Given this list of marker genes ANKRD28, RARRES2, ORMDL2, DAB1, PRR5, CCNA1, COL6A1, PRPF39, CTNND2, NOTCH4 (NCBI Gene Id 4855), ATE1, TGFB2, YIF1A, CUL1, SRY, HLA-G, LTF, SNORC, VPS16, CLVS1, FUT9, CASQ1, STK25, SLC25A15, S100A4, CETN1, INTS14 (integrator complex subunit 14), HOXA4, IRF7, EBP, TMEM168, PTPRB, SSR1, PEG10, PGR, PKIB, BAAT, MYH6, DNPH1, SNCA, KCNK7 (potassium two pore domain channel subfamily K member 7), AADAC, DPYSL4, EPHB6, RRAGD, CDC37, TMEM266, MMS19, SERPINF2, ASL, CNTN1, APOF, INPP4A, ACTR6, C9orf85, TCF21, GHRH, ACTN2, BHMT, HLA-A, MYCN, UBE2J2, SOX5, CRAMP1, ILRUN, SOX2, PNMT, SLC35B2, PLD4, NRGN, CSF3R, MAPK13, SUPT6H, CPSF7 (NCBI Gene Id 79869), COQ9, COMMD5 (COMM domain containing 5), INTS5, CLEC3B, RETN, ACY3, ZNF865, RPS6KA4, TGFB3, DPPA2, GPR143, DALRD3, GNAT2, RPL35A, GBA1, RBL2, GTPBP2 (NCBI Gene Id 54676), MYH3, SOD1, SMTN, PRRC1, CLEC16A (C-type lectin domain containing 16A), ERG28, BHLHE40, GUCA1A, PER3, HMGCR, TENM4, RAF1, AVPR1A, H1-3, KIAA1217, FERMT3, LCAT, DTD2, SMC6, DHRS7B, USP17L2, PDLIM1, MOGAT2, ITK, INS, RETSAT, SCGB1A1, RAI2, PRAP1, ZG16, ADRA1A, FGF6, POLB, RPA1, ZMAT3, EPYC, XIRP1, KGD4, GLRA1, BCL7B, AP2M1, LIMK1, NDUFA12, KRTAP19-5, MYNN, RIC8A, BEX1, MTCP1, C1orf174, SRPK3, EPHA3, PIGF, ARHGEF2 (Rho/Rac guanine nucleotide exchange factor 2), DDR2, METTL17, ZIC1, SFN, IDH1, FLT3LG, EFNA3, CYP7B1, PLA2G7, RABEPK, FGF5, TOMM40, SLC25A19, BAIAP2, HIPK1, COP1, SLC1A1, IGLC7, UBE2F, SCG3, IQGAP2, ADA, BNIP2, HAGH, ASAH1, WNT5B, ADGRL1, MAP3K11, TMOD3, MRPL12, VAMP8, TUBA3C, TM4SF5, CNGA1, AKR1C4, STRN4, TRIM11, CBX6, WDR55, RING1, GGPS1, B4GALT3, FAP, COL4A4, COL26A1, FKBP5, CBX7, PLPP1, IRF3, HSD17B2, MAD2L1BP, CIITA, C1R, TBRG1, MCCC1, ANG, here is a description of the gene set: Genes down-regulated in CD42 int cells from thymus: T reg versus T conv. from publication Toker A, Engelbert D, Garg G, Polansky JK, Floess S, Miyao T, Baron U, Düber S, Geffers R, Giehr P, Schallenberg S, Kretschmer K, Olek S, Walter J, Weiss S, Hori S, Hamann A, Huehn J (PMID 23420886) studied in species Homo sapiens We investigated at which stage of maturation commitment to a stable Foxp3-expressing phenotype takes place. We assessed stability of Foxp3 expression in thymic Foxp3+ Treg subsets of different maturity, defined by CD24 expression. Next we compared gene expression profiles of Foxp3+ Treg subsets (+) of different maturity (24lo, 24int, 24hi) and could identify a set of genes that were specifically up or downregulated in Foxp3+ Tregs, but not in Foxp3- conventional T cells, in a maturation-dependent manner. Human Gene Set: GSE42021_CD24INT_TREG_VS_CD24INT_TCONV_THYMUS_DN